Given this list of marker genes Foxo4, P2ry10b, Itgav, Lrrc1, Fmn1, Slc35f6, Gna11, Taok1, Atxn1l, Spag17, Fkbp1a, Apc, Morf4l2, Zbtb41, Ptbp3, Epn1, Slc37a3, Zeb2, Irak1, Pou2f1 (POU domain, class 2, transcription factor 1), Rictor, Inpp5a, Dnaaf9, Fmnl2, Zfp654, Cpeb2, Smug1, Tor1aip2, Dsel, Egfl6, Stx12, Rab12, Lcorl, H2bc24, Fabp4 (NCBI Gene Id 16804), Vamp5, Ptpn23, Kdelr2, Ash1l, Rac1, H2bc23, Hgs, Kif5b, Zfp217, Sptssb, Rheb, Gorab, Akt1s1, Atf7ip, Fyco1, Baz1a, Slc49a4, Rock2, Pank1, D1Pas1, Stam, Fbxl17, Pgm1, Myh10, Mlxip, Rab2a, Pawr, Ctsm, Pramel3a, Tsen34, Mbd6, Il6st, Tiparp, Mark3, Bod1, Tmem47, Dnah11, Slc39a10, Bmal1, Hectd1, Twf1, Nap1l5, Brwd3, Rbm47, Acbd5, Gpatch11 (G patch domain containing 11), Tnks (tankyrase, TRF1-interacting ankyrin-related ADP-ribose polymerase), Utrn, Tardbp, Mc4r, Tbc1d2b, Osbp, Tab2, Wasl, Cd2ap, Suco, Strn3, Sh2b1, Pou2af2, Pramel3e, Cd8a, Tasor2, Atp2a2, Tjp1, Rras, Gtf2a1, Nr3c1 (NCBI Gene Id 14815), Pde4b, Tgfbr1, Kat2b, Grb14, Ppp1r37, Golga1, Cfl2, Elovl4, Clock, Rab23, Pip4p1, Cask, Tmem59, Tnrc18, Rab40c, here is a description of the gene set: Mouse Gene Set: MIR_142A_3P from publication Chen Y, Wang X (PMID 31504780) Genes predicted to be targets of miRBase v22 microRNA mmu_miR_142a_3p in miRDB v6.0 with MirTarget v4 prediction scores > 80 (high confidence targets). species: Mus musculus